Given this list of marker genes BGN, CSPG4, VCAN, GPC1, PAPSS2, B4GALT1, KERA, FMOD, GPC3, SDC3, HEXB, CHST6, SDC2, B4GALT7, CHSY1, SLC26A2, AGRN, OGN, B3GALT6, GPC5, CSPG5, BCAN (brevican), OMD, HSPG2, HEXA, GPC2, LUM, SDC1, PRELP, NCAN, EXT2, GPC4, EXT1, DCN, SDC4, ACAN, CHST3, B3GAT3, GPC6, ST3GAL3, CHST14, here is a description of the gene set: studied in species Homo sapiens Diseases associated with glycosaminoglycan metabolism Human Gene Set: REACTOME_DISEASES_ASSOCIATED_WITH_GLYCOSAMINOGLYCAN_METABOLISM